Given this list of marker genes POLK, BAK1, DDB2, USP7, TP53, GADD45A, GADD45G, BAX, CDKN1A, GADD45B, here is a description of the gene set: species: Homo sapiens EBV EBNA1 to p53-mediated transcription. Pathway ID: N00223. Pathway type: Pathogen. Pathway class: nt06165 Epstein-Barr virus (EBV). Human Gene Set: KEGG_MEDICUS_PATHOGEN_EBV_EBNA1_TO_P53_MEDIATED_TRANSCRIPTION Pathway Definition from KEGG: EBNA1 -| USP7 -> TP53 => (CDKN1A,GADD45,BAX,BAK1,DDB2,POLK)